Given this list of marker genes Efna1, Ifngr1, Ranbp9, Slc2a13, Gsk3a, Prnp (NCBI Gene Id 98923), Casp3, Epha4, Csnk1e, Flot2, Rock1, Gga3, Sorl1, Ager, Rps23rg1, App, Unc13a, Rela, Clu, Picalm, Rtn1, Rtn3, Abca2, Apoe, Lyn, Sp1, Tnf, Hap1, Abcg1, Spon1, Pin1rt1, Rock2, Ntrk2 (NCBI Gene Id 77471), Chrna7, Efna3 (NCBI Gene Id 99908), Abca7, Lrrtm3, Pin1, Ifng, Tmed10, Rtn4, Bin1, Rtn2, Igf1, Tmed10-ps, Gsap, here is a description of the gene set: Any process that modulates the frequency, rate or extent of amyloid precursor protein catabolic process. studied in species Mus musculus Mouse Gene Set: GOBP_REGULATION_OF_AMYLOID_PRECURSOR_PROTEIN_CATABOLIC_PROCESS